Given this list of marker genes PRKCA, CACTIN, DEFB118, IRAK1, LTF, SPI1, LY86, TRIB1, LBP (NCBI Gene Id 3929), TRIM5, MAPK1, TICAM1, DEFB114, CD180, HCK, SCIMP, BMP6, MALT1, JAK2, TNFAIP3, MIF, MYD88, NOS3, LYN, CD6, PTPN11, PRDX2, TIFAB, TLR2, MAPK14, CD36, ACOD1, CARD8, NFKBIA, AKT1, LACRT, SCARB1, MAPK3, NFKBIL1, IRAK3, LY96 (NCBI Gene Id 23643), PTAFR, PLCG2, CD55, PTPN6, SASH1, CARD16, IRAK4, MTDH, IRAK2, CX3CL1, SIRPA, SIGIRR, IRF3, BCL10, PRKCE, TLR4, CD14, TRAF6, BPI, RIPK2, LILRA2, PTPN22, here is a description of the gene set: studied in species Homo sapiens Human Gene Set: GOBP_LIPOPOLYSACCHARIDE_MEDIATED_SIGNALING_PATHWAY The series of molecular signals initiated by the binding of a lipopolysaccharide (LPS) to a receptor on the surface of a target cell, and ending with the regulation of a downstream cellular process, e.g. transcription. Lipopolysaccharides are major components of the outer membrane of Gram-negative bacteria, making them prime targets for recognition by the immune system.